The following is a description of a gene set: Catalysis of the reaction: a long-chain fatty acyl-CoA + H2O = a long-chain fatty acid + CoA + H+. A long-chain fatty acid has an aliphatic tail containing 13 to 22 carbons. species: Homo sapiens Human Gene Set: GOMF_LONG_CHAIN_FATTY_ACYL_COA_HYDROLASE_ACTIVITY, and this is the list of marker genes: BAAT, ACOT9, ACOT11, PPT1, ENSG00000293349, ACOT7, PLA2G6, MBLAC2, CLN5, ACOT8, DESI2, HADHA, THEM4 (NCBI Gene Id 117145), THEM5, DESI1